Given this list of marker genes Prkg2 (NCBI Gene Id 19092), Pde11a, Cnga3, Prkg1, Pde6h, Cngb3, Cnga1, Pde6c, Cnga4, Pde5a, Pde2a, Pde6g, Pde10a, Cnga2, Cngb1, here is a description of the gene set: Binding to cGMP, the nucleotide cyclic GMP (guanosine 3',5'-cyclophosphate). Mouse Gene Set: GOMF_CGMP_BINDING studied in species Mus musculus